Given this list of marker genes MAP3K7, MARCHF5, BTK, SLC19A1 (NCBI Gene Id 6573), ZDHHC9, TAB1, RNF39, here is a description of the gene set: studied in species Homo sapiens Any process that activates or increases the frequency, rate or extent of of cGAS/STING signaling pathway. Human Gene Set: GOBP_POSITIVE_REGULATION_OF_CGAS_STING_SIGNALING_PATHWAY